Given this list of marker genes EIF2S2, ATF5, PPP1R15A, EIF2AK1, DDIT3, CEBPB (NCBI Gene Id 90277), CEBPG, ATF3, EIF2S3, EIF2S1, CHAC1, TRIB3, ATF4, ASNS, GRB10, here is a description of the gene set: Response of EIF2AK1 (HRI) to heme deficiency species: Homo sapiens Human Gene Set: REACTOME_RESPONSE_OF_EIF2AK1_HRI_TO_HEME_DEFICIENCY